The following is a description of a gene set: PINK1-PRKN Mediated Mitophagy species: Homo sapiens Human Gene Set: REACTOME_PINK1_PRKN_MEDIATED_MITOPHAGY, and this is the list of marker genes: UBE2D2, ATG5, TOMM5, UBA52, SQSTM1, UBE2D3, TBK1, VDAC1, MAP1LC3A, TOMM22, OPTN, UBC, VDAC3, ATG12, MAP1LC3B, TOMM20, TOMM70, TOMM40, TOMM6, PINK1, RPS27A, UBE2L3, TOMM7, MFN1, VDAC2, UBB, ATG9A, MFN2, MTERF3, UBE2N, PRKN, UBE2V1